The following is a description of a gene set: Genes down-regulated in osteoblasts from wild type male mice compared to those with AR knockout. from publication Kang HY, Shyr CR, Huang CK, Tsai MY, Orimo H, Lin PC, Chang C, Huang KE (PMID 18838539) While androgen receptor (AR)-deficient mice developed osteopenia in endochondral bones due to the high bone turnover with increased bone resorption by osteoclasts, little is known about the mechanism of intramembranous bone loss contributed by AR in osteoblasts. Here, we discovered a dramatic decrease in the area of calcification, new bone, and the number of osteocytes in calvaria from AR-deficient mice related to a reduction in mineralization caused, in part, by the diminished activity of AR-deficient osteoblasts. Enforced AR expression in differentiated osteoblasts boosts mineralization while knockdown of AR expression prevents androgen-induced mineralization. We identified the tissue-nonspecific alkaline phosphatase (TNSALP) and several members of small integrin binding ligand N-linked glycoprotein (SIBLING) gene family as androgen target genes required for AR-mediated bone formation. We show that inorganic phosphate (P(i)) levels and TNSALP activity increased in response to androgen/AR and P(i) signals increase the expression and translocation of AR. The ectopic expression of TNSALP or P(i) partially rescued the bone loss due to AR deficiency. Thus, androgen/AR signaling plays an essential role in bone formation by coordinating the expression of genes associated with phosphate regulation. studied in species Mus musculus Mouse Gene Set: KANG_AR_TARGETS_DN, and this is the list of marker genes: Dmp1, Spp1, Vegfa, Ctsk, Fgf1, Itgb1, Vegfb, Col1a2, Slc20a1, Col1a1, Alpl, Dspp, Anxa5, Mepe, Mmp8, Tgfb1, Smad1, Slc20a2